Given this list of marker genes Gdf5, Bmpr1a, Comp, Hjv, Chrdl1, Grem2, Tgfbr3, Nbl1, Eng, Bmpr2, Chrd, Tcap (titin-cap, NCBI Gene Id 21393), Cer1, Agrn, Sostdc1, Sost (NCBI Gene Id 74499), Scube3, Grem1, Ucma, Chrdl2, Bmpr1b, here is a description of the gene set: species: Mus musculus Mouse Gene Set: GOMF_BMP_BINDING Binding to a member of the bone morphogenetic protein (BMP) family.